Given this list of marker genes PRKAG1, PRKAR2B, PPP1R1B, PRKAR1A, PRKAR2A, CXCL10, PRKAR1B, PKIG, PKIB, SMO, PRKAG2, PKIA, here is a description of the gene set: Human Gene Set: GOMF_CAMP_DEPENDENT_PROTEIN_KINASE_REGULATOR_ACTIVITY Modulation of the activity of the enzyme cAMP-dependent protein kinase. species: Homo sapiens